Given this list of marker genes DNAJC21, SLC4A4, SBDS, EFL1, NFS1, CNOT1, here is a description of the gene set: Abnormal circulating amylase concentration studied in species Homo sapiens A deviation from the normal concentration of amylase in the blood, an enzyme which helps digest glycogen and starch. It is produced mainly in the pancreas and salivary glands. Human Gene Set: HP_ABNORMAL_CIRCULATING_AMYLASE_CONCENTRATION